Given this list of marker genes KLB, SHC1, KRAS, FGF1, FGF20, FGF9, FGF6 (NCBI Gene Id 2251), FGF4, FGF19, FGF8, FGF16, HRAS, FGFR4, FGF18, FGF23, FGF17, FGF2, GRB2, SOS1, NRAS, here is a description of the gene set: Reactome Pathway: SHC-mediated cascade:FGFR4 part of: Downstream signaling of activated FGFR4 studied in species Homo sapiens The exact role of SHC1 in FGFR signaling remains unclear. Numerous studies have shown that the p46 and p52 isoforms of SHC1 are phosphorylated in response to FGF stimulation, but direct interaction with the receptor has not been demonstrated. Co-precipitation of p46 and p52 with the FGFR2 IIIc receptor has been reported, but this interaction is thought to be indirect, possibly mediated by SRC. Consistent with this, co-precipitation of SHC1 and FGFR1 IIIc is seen in mammalian cells expressing v-SRC. The p66 isoform of SHC1 has also been co-precipitated with FGFR3, but this occurs independently of receptor stimulation, and the p66 isoform not been shown to undergo FGF-dependent phosphorylation. SHC1 has been shown to associate with GRB2 and SOS1 in response to FGF stimulation, suggesting that the recruitment of SHC1 may contribute to activation of the MAPK cascade downstream of FGFR.